Given this list of marker genes SIGMAR1 (sigma non-opioid intracellular receptor 1), TBK1, GLE1 (NCBI Gene Id 8012), SMN2, ASAH1, AGTPBP1, EXOSC8, VAPB, KIF5A, TRPM7, GRN, UNC13A, SPG11, RBM28, CNTNAP2, TIA1, CEP55, VPS41, ERBB4, PON1, UBA1, ANG, ANXA11, PLEKHG5, C9orf72, EXOSC9, FUS, SETX, SLC25A46, GLT8D1, OPTN, PRPH, SPTLC1, MTOR, MATR3, PON3, ALDH18A1, DCTN1, TREM2, IGHMBP2, MAPT, C19orf12, NEFH, TFG (NCBI Gene Id 50989), AKT3, TYROBP, TUBA4A, VRK1, CHCHD10, HNRNPA1, CYLD, ERLIN2, TAF15, PON2, SOD1, ALS2, FIG4, CFAP410, UBQLN2, VPS13D, VCP, CEP126, PNPLA6, TARDBP, PPARGC1A (PPARG coactivator 1 alpha), CCNF, TMEM106B, PFN1, ATXN2, PRKAR1B (protein kinase cAMP-dependent type I regulatory subunit beta), EXOSC3 (exosome component 3), SPG7, ZNF335, SQSTM1, CHMP2B, NEK1, SMN1, GBE1, PIK3CA, ATXN3, DAO, SERPINI1, PSEN1, CPLANE1, HNRNPA2B1, here is a description of the gene set: Abnormal neuron morphology Human Gene Set: HP_ABNORMAL_NEURON_MORPHOLOGY A structural anomaly of a neuron. Neurons are electrically excitable cells that transmit signals throughout the body. Neurons employ both electrical and chemical components in the transmission of information. Neurons are connected to other neurons at synapses and connected to effector organs or cells at neuroeffector junctions. studied in species Homo sapiens